Given this list of marker genes Rad21, Tmsb15b1, Tcte1, Gna15, Cd59b (CD59b antigen), Kcnma1, Sln, Gata1, Ubqln3, Igf1r, Prickle2, Sbf2, Blzf1, Pdxk, Lancl2, Ccl6, Srsf2, Gch1, Rreb1, Igfbp7, Wdr33, Nfix, Adgrb3, Fam120c, Acsl3, Hivep2, Bmp2, Zscan22, Mrpl21, Ola1, Gpm6a, Dennd1b, Rtcb, Cdadc1, Azgp1, Trim25, Adgrl2, Cd59a, Cd209e, Catsperg2, Has2, Pttg1ip, Ppargc1a, Capn6, here is a description of the gene set: Mouse Gene Set: MIR_344G_5P from publication Chen Y, Wang X (PMID 31504780) Genes predicted to be targets of miRBase v22 microRNA mmu_miR_344g_5p in miRDB v6.0 with MirTarget v4 prediction scores > 80 (high confidence targets). species: Mus musculus